Given this list of marker genes SDHD, ACAD9, DHODH, ACADSB, COX15, FASN, CYP2S1, ACOX3, ACAD10, ACAA1, RETSAT, SDHB, TECR, LBR, CRAT, ACADS, DHCR7, ACAD11, DHDH, AKR1C2, RSAD1, ACADM, BLVRB, PTGES2, GCDH, ACOX1, TM7SF2, PPOX, SRD5A2, AKR1C3, TBXAS1, IVD, PTGR3 (prostaglandin reductase 3), AKR1D1, ACADL, DECR1, DPYD, TECRL, PECR, SRD5A3, DUS2, BLVRA, DUS1L, ACOX2, ACAD8, SDHA, PTGR1, DECR2, DHRSX, PTGR2, DHCR24, ACOXL, ACADVL, DUS4L, SRD5A1, BDH2, CPOX, AKR1C1, DUS3L, MECR, here is a description of the gene set: species: Homo sapiens Catalysis of an oxidation-reduction (redox) reaction in which a CH-CH group acts as a hydrogen or electron donor and reduces a hydrogen or electron acceptor. Human Gene Set: GOMF_OXIDOREDUCTASE_ACTIVITY_ACTING_ON_THE_CH_CH_GROUP_OF_DONORS